The following is a description of a gene set: Lectin pathway of complement cascade, C4/C2 to C3 convertase formation. Pathway ID: N01491. Pathway type: Reference. Pathway class: nt06513 Complement cascade. Human Gene Set: KEGG_MEDICUS_REFERENCE_LECTIN_PATHWAY_OF_COMPLEMENT_CASCADE_C4_C2_TO_C3_CONVERTASE_FORMATION Pathway Definition from KEGG: -- ((MBL2,COLEC10/11,FCN)+MASP1/2) -> -> (C4b+C2a) studied in species Homo sapiens, and this is the list of marker genes: FCN1, C4B, C4A, FCN3, MBL2, MASP1, COLEC10, FCN2 (ficolin 2), COLEC11, MASP2, C2